Given this list of marker genes Eef1akmt1, Calm3, Eef2, Camkmt, Prmt3, Calm2, Etfb, Hspa8, Mettl22, Calm1, Eef1a1, Vcpkmt, Rps2, Vcp, Kin, Eef2kmt, Etfbkmt, Mettl21a, Eef1akmt2, here is a description of the gene set: Protein methylation Mouse Gene Set: REACTOME_PROTEIN_METHYLATION studied in species Mus musculus